The following is a description of a gene set: Human Gene Set: GOBP_REGULATION_OF_FATTY_ACID_BETA_OXIDATION Any process that modulates the frequency, rate or extent of fatty acid bbeta-oxidation. species: Homo sapiens, and this is the list of marker genes: PPARA, ACACB, LONP2, ABCD1, AKT1, MTLN, PLIN5, ABCD2 (NCBI Gene Id 225), IRS1, MLYCD, CPT1A, AKT2, TYSND1, TWIST1, ABCB11, IRS2, MFSD2A, ETFBKMT